The following is a description of a gene set: studied in species Homo sapiens part of: Degradation of beta-catenin by the destruction complex Reactome Pathway: Beta-catenin phosphorylation cascade Degradation of beta-catenin is initiated following amino-terminal serine/threonine phosphorylation. Phosphorylation of B-catenin at S45 by CK1 alpha primes the subsequent sequential GSK-3-mediated phosphorylation at Thr41, Ser37 and Ser33., and this is the list of marker genes: GSK3B, PPP2R5A, CTNNB1, AMER1, APC, CSNK1A1, PPP2CB, FRAT1, PPP2R1A, PPP2R5E, PPP2R5D, AXIN1 (axin 1), PPP2R5C, PPP2CA, PPP2R5B, FRAT2, PPP2R1B (NCBI Gene Id 5519)